Given this list of marker genes S100G, AZGP1P1, ABL2, HMOX1, FUT7, CROCCP3, ATF3, ASNS, RIPPLY3, INSIG1, ATF4, SLC3A2, NOS1, GCNT3, GPR148, DDIT3, HERPUD1, HOXD10, CTH, BIRC3, TNNT2, ABCC6, HLCS, GRPEL2, PDCD1, PPP1R15A, ADAMTS10 (NCBI Gene Id 81794), NOX4, EXTL1, KDM5A, PIGZ (phosphatidylinositol glycan anchor biosynthesis class Z), EAF1 (NCBI Gene Id 85403), here is a description of the gene set: species: Homo sapiens Nerve growth factor-induced Balpha (NGFI-Balpha, Nur77) is an orphan nuclear receptor with no known endogenous ligands; however, recent studies on a series of methylene-substituted diindolylmethanes (C-DIM) have identified 1,1-bis(3'-indolyl)-1-(phenyl)methane (DIM-C-Ph) and 1,1-bis(3'-indolyl)-1-(p-anisyl)methane (DIM-C-pPhOCH3) as Nur77 agonists. Nur77 is expressed in several colon cancer cell lines (RKO, SW480, HCT-116, HT-29, and HCT-15), and we also observed by immunostaining that Nur77 was overexpressed in colon tumors compared with normal colon tissue. DIM-C-Ph and DIM-C-pPhOCH3 decreased survival and induced apoptosis in RKO colon cancer cells, and this was accompanied by induction of tumor necrosis factor-related apoptosis-inducing ligand (TRAIL) protein. The induction of apoptosis and TRAIL by DIM-C-pPhOCH3 was significantly inhibited by a small inhibitory RNA for Nur77 (iNur77); however, it was evident from RNA interference studies that DIM-C-pPhOCH3 also induced Nur77-independent apoptosis. Analysis of DIM-C-pPhOCH3-induced gene expression using microarrays identified several proapoptotic genes, and analysis by reverse transcription-PCR in the presence or absence of iNur77 showed that induction of programmed cell death gene 1 was Nur77 dependent, whereas induction of cystathionase and activating transcription factor 3 was Nur77 independent. DIM-C-pPhOCH3 (25 mg/kg/d) also inhibited tumor growth in athymic nude mice bearing RKO cell xenografts. These results show that Nur77-active C-DIM compounds represent a new class of anti-colon cancer drugs that act through receptor-dependent and receptor-independent pathways. Human Gene Set: CHO_NR4A1_TARGETS Genes up-regulated in RKO cells (colon cancer) after treatment with the NR4A1 agonist, DIM-C-pPhOCH3. from publication Cho SD, Yoon K, Chintharlapalli S, Abdelrahim M, Lei P, Hamilton S, Khan S, Ramaiah SK, Safe S (PMID 17234778)